Given this list of marker genes GGA2, IGFBP3, SCAMP1, NHLH2, PPP4R3B, ARHGEF5, PYY2, PIANP, SMG1, NUP153, CNPY3, PNCK, NLGN1, ARL6IP1, ZIC3, TAL1, OSBP, NLK, ATP6V1A, FBXO21, SLC32A1, DDX11, SAR1A, IL1RAP, CMTM4, SYNGAP1, PCDH19, ACACA, SELENOI, DNM1, HERC4, KCND2, CILP, FBXO33, DPP3, RAB28, TTLL7, KLHL14, ETF1, PHF20L1 (NCBI Gene Id 84165), BRCA1, ZNF827, ASB15, SPPL3, AGAP2, FBXW7, RBM38, RNF26, TXLNG, SMYD5, PABIR2, GATAD2B, DUOXA2, DDX52, UBE2R2, AGO2, KCNIP2, PPM1E, SYNGR1, GRIN1, ANK2, HNRNPD, MAPK4, BCL7A (NCBI Gene Id 605), OTUB1, PTPN9, GRIA2, ARMC1, CTNND1, ADGRL3, USP4, EBF1, here is a description of the gene set: Genes having at least one occurence of the motif GTGGTGA in their 3' untranslated region. The motif represents putative target (that is, seed match) of human mature miRNA hsa-miR-197 (v7.1 miRBase). Human Gene Set: GTGGTGA_MIR197 studied in species Homo sapiens